The following is a description of a gene set: Expression microarray analysis identified over genes regulated during puberty in the mouse mammary gland. Most prominent were genes whose expression increased in parallel with pubertal development and remained high thereafter. Members of the Wnt, transforming growth factor-beta and oestrogen-signalling pathways were significantly overrepresented. Comparison to expression data from CITED1 knockout mice identified a subset of oestrogen-responsive genes displaying altered expression in the absence of CITED1. Included in this subset are stanniocalcin2 (Stc2) and amphiregulin (Areg). Chromatin immunoprecipitation revealed that ERalpha binds to oestrogen response elements in both the Stc2 and Areg genes in the mammary gland during puberty. Additionally, CITED1 and ERalpha localize to the same epithelial cells of the pubertal mammary gland, supporting a role for interaction of these two proteins during normal development. In a human breast cancer data set, expression of Stc2, Areg and CITED1 parallel that of ERalpha. Similar to ERalpha, CITED1 expression correlates with good outcome in breast cancer, implying that potential maintenance of the ERalpha-CITED1 co-regulated signalling pathway in breast tumours can indicate good prognosis. Mouse Gene Set: MCBRYAN_PUBERTAL_BREAST_5_6WK_UP from publication McBryan J, Howlin J, Kenny PA, Shioda T, Martin F (PMID 17486082) studied in species Mus musculus Genes up-regulated during pubertal mammary gland development between week 5 and 6., and this is the list of marker genes: Enpp3, Ctla2a, Ehhadh, H2-Aa, Ppp1r3c, Dmac2, Ppp1r8, Cldn8, Tpp2, Tmem109, Ednra, Spin1, Siah2, Tfap2c, Ndrg1, Tjp2, Tjp3, Ube3a, Dnajc12, Ocln, Mtarc1, Unc50, Mmp3, Slc44a2, Slc15a2, Pam, Grhl1, Penk, Prss23, Cd8a, Sftpd, Acsf2, Akr1c14, Tpm2, Kitl, Nup54, Anpep, Atp1b1, Cldn7, Erbb3, Krt5, Arg2, Mmd2, Myb, Csn1s2a, Klf5, Fhl1, Nipal2, Fxyd3 (FXYD domain-containing ion transport regulator 3), Bltp3a, Acot1, Serpina3k, Blcap, Csn2, Tnfrsf21, Tlcd4, Zbtb16, Has2, Sox13, Clu, Elf1, Ccnk (NCBI Gene Id 12454), Prkag2, Cisd1, Snrnp27, Sftpb, Golph3, Ktn1, Fblim1 (filamin binding LIM protein 1), Tspan17, Idh1, Rcc1l, Cyp4v3, Kcnk1, Rnf149, Art3, Socs6, Prom2, Pawr, Stxbp6, Scara5 (scavenger receptor class A, member 5), Pfkfb3, Lipa, Tmem14c, St6galnac5, Rad1, Eral1, Rnf2, Cirbp, S100a8, Cfap298, Avl9, Bche, Wee1, Socs2, Mis12, Ezr (NCBI Gene Id 97496), Csn1s1, Retnla, Lgals12, Slc25a24, Tmem45b, Pkp2, Rnd3, Ceacam1, Net1, Psip1, Spp1, Nfe2l3, Lsm14b, Nipsnap3b, Pdk4, Sfxn1, Klhl2, Mlph (NCBI Gene Id 98687), Pdgfc (platelet-derived growth factor, C polypeptide), Galnt7, Dsg2, Mboat1, Seh1l, Tcf7, Hspa1b, Pcolce2, Muc15